Given this list of marker genes SAMD3, CRIM1, KANSL1L, DHX33, RAI1, CCNL2, CCZ1, IFT25, SLC35E2A, C5orf22, AP1S2, EOMES, ING4, L3HYPDH, CROCCP2 (NCBI Gene Id 84809), DCAF10, DOCK9, TFB1M, OMA1, METAP1, DCAF6, MTREX, CD300A, MTO1, DDI2, DNAAF10, NFATC3 (nuclear factor of activated T cells 3, NCBI Gene Id 82543), SLC4A1AP, CAPG, CSF2RA, GSTK1, PSMD14, CD84, RARS1, ANXA2, NBPF12, IRF3, VIPAS39, TBC1D9B, DIP2A, NUDCD1, UQCR10, DUSP18, RUVBL1, CISD1, ARMT1, ARMC8, FLT4 (fms related receptor tyrosine kinase 4), MEAK7, OGG1, LONP1, KIAA0319L, TMEM223, TDRD7, UBA1, HGSNAT, RETREG3, EXOC5, CBX1, STT3A, KHDC4, PRDX1, DLGAP4, ATPAF1, MAPK1, ZGPAT, EIF1, HNMT, SMARCAD1, AGAP4, MCMBP (minichromosome maintenance complex binding protein), CHD9, PNKD, EPS15, PDHB, IFFO1, PCMT1, EEA1, BICD2, IPO9, MED13L, CEP85, DARS1, SPOP, GALM, USP28, UBXN8, FAM111A, TM7SF3, HAUS1, HUWE1, LAT, OSGEPL1, SDAD1, ZNF354A, UVSSA, UBN2, FEZ2, ABCF2, ZNG1A, AHCYL2 (NCBI Gene Id 23382), MNDA, EIF2S1, MLEC, USP21, MRPL18, C3AR1, TRADD, HSD17B4, FADS1, SYNGR2, HDDC3, SRPRB, ZNF514, TES, DHX16, G3BP1, CTSC, IDE, SLC7A1, SRSF7, ZNF721, LUC7L, CRYBG3, SLC35B3, GIMAP2, GZMA, ZRSR2, GRSF1, MBNL2, LUC7L2, AKAP10, FUS, OXR1, RAD51C, WASH3P, AGPAT3, ELOVL1, TMEM50B, MRPS9, SLF2, HIBCH, CBFA2T2, IL17RA, ARHGAP26 (NCBI Gene Id 23092), RSBN1L, ALG13, KCNE3, ANAPC7 (anaphase promoting complex subunit 7), MUS81, NSRP1, RNF146, NUP43, GCN1, DNAJC17, C8orf44, ABRAXAS1, CPSF3, ESYT2, AP1AR, DNAJC16, MED11, ZNF148, TMEM250, ARL11, SKA2, PMS2P1, ETNK1, CACNA2D3, TTYH2 (tweety family member 2), NAPB (NSF attachment protein beta), TARDBP, PFKP, LRRC37A2, SLC30A7, CCZ1B (NCBI Gene Id 26113), STIP1, ME2, NNT, PURA, NBR1, STYX, CD4, H1-3, PCID2, MBNL1, ALG6, HEXB, LILRA4, MDM1 (Mdm1 nuclear protein, NCBI Gene Id 56890), RIOX2, MRS2, FCF1, CELF1 (CUGBP Elav-like family member 1), NUP42 (nucleoporin 42), CLPTM1L, HSPBAP1, NEAT1, UTP14C, WSB1, ARMC10, CASP2, NAIP, CDC14A, CIAPIN1, CAPRIN1, CBR4, CLPX, LRCH3, GGCT, COQ9, SLC25A11, ZNF573, LARS1, COMMD10, P2RX7, ATM, AMY1C, DPY30, TRAPPC8, HDHD2, PDHA1, COASY (Coenzyme A synthase), TIPRL, FKBP15, GNL2, DIDO1, SNAPIN, EIF2B4 (NCBI Gene Id 8890), ZNF641, BIVM, PAFAH1B1, USO1, ATP13A1, CD53, PREB, TK2, ZNF767P, BRD8, RBM42 (RNA binding motif protein 42), C2CD5, ECHDC1, RASA1, ZNF146, RSF1, IARS1, ENTR1, PPP3CB, SMC5, SCAMP1 (secretory carrier membrane protein 1), TMX3, GNPDA1, LGALS1, SCPEP1, AMY2A, DPP3, MTIF3, NHLRC3, NR2C2, EDEM3, NSF, NSUN5P1, POU2F2, RAB7A, NBPF1, LYRM7, APPBP2, STAG3L1, PMS1, HDAC9, GSAP, MRPS18B, MTIF2, ENSG00000272447, DUSP22, OTULINL, BRD10, ZNG1E, SLC7A6, NUDT7, NIT2, ACER3, GANAB, TNIP1, SIGMAR1, MACROH2A1, RAD50, DNM1L, NCOA3, PPIE, KDELR1, RBM8A, UBE4A, GSE1, YEATS2, SUGP2, SDCCAG8, KLHDC4, WDR12, EXOC4, C11orf21 (NCBI Gene Id 29125), VCAN, RASA4, B3GALNT2, NOTCH2, WDR73, TXNDC15, EIF3J, SAMHD1, CREBBP, FAM78A, UBA7, PRIMPOL, CDK4 (NCBI Gene Id 92978), RAD17, MRTO4, CD160, DOK2, POGZ, CACNA2D4, SLC66A3, NMT2, STK38, COX18, SPTLC2, IL27RA, SAE1, GPD1L, ARMC1, SLC38A10, SNX19, PRDX3, SP1, PIGG, SMC1A, DENND4B, SNUPN, ANAPC1, RTN4, PARN, COG2, CCND3, DIS3L, CUL1, TRAF5, CCT7, RAD1, MS4A7, KATNBL1, H2BC8, VIPR1, MKLN1, DDX23, ENGASE (endo-beta-N-acetylglucosaminidase), INTS8, GTF2E1, KAT2B, ZNF280D, ATP6AP1, PYCR2, PTGDR, LIAS, SHQ1, PNPT1 (NCBI Gene Id 87178), TTC9C, IP6K2, GALNT7, ZNF207, ZNG1B, NDUFA8, PAPSS2, CDC25B, CTSB, AGL, ITGB2 (NCBI Gene Id 3689), GPATCH4, RNPC3 (NCBI Gene Id 55599), INSR, PSD4, CREB3L2, AP1M1, COA5, MCM3 (NCBI Gene Id 4172), ORMDL1, SETX, INTS10, RASAL3, KDELR2, SPAST, MCCC2, GTF2A1, TBCK, PID1, AMY2B, FYB1, SAMD9L, SNX5, NCBP2, NCSTN (NCBI Gene Id 57297), TNFAIP8L2, RBM6, INPP4A, TMX2, NMRAL1, NAA25, MPHOSPH9, GLCCI1, HYOU1, NSUN5P2, TRIM44, TET2, CREB1, TTC1, SPCS2, DIS3L2, UBASH3A, RIPOR2, IRAK3 (NCBI Gene Id 11213), PIK3C3, APEH, TCTN3, GOPC, WBP1L, DCAF13, MICAL2 (NCBI Gene Id 9645), CLN8, TFCP2, EZH1, JAML, ASCC1, GPD2, HECA, FGD2, CASP6, CEP350, PITRM1, USP48, SULT1A2, PUS7, POLR3K, IQGAP2, RALA, GATAD1, COPS7A, CDK8, ATXN2, DCLRE1B, PAK1 (p21 (RAC1) activated kinase 1), NBPF9, MAD1L1, MGA, ZC3H6, VPS72, TMEM218, EWSR1, FKBP5, NDUFV3, YPEL2 (NCBI Gene Id 388403), OGFOD1, ZFP64, PDE6D, TRIM4, ALDH3A2, ATRN (NCBI Gene Id 8455), INTS13, EHMT1, CDC16, PRMT2, GSR, DCAF7, TBCE, ZDHHC13, PALB2, CRLS1, VPS50, PRKAG1, EIF4ENIF1, NFYC, KLHL8, KDM5A, NEK2-DT, G6PC3, TRIM56, RUSC1-AS1, ERI1, SRFBP1, KIDINS220, MBOAT1, BRWD1, ZNF862, ZNG1C, ZNF789, SNX1, PHF14 (NCBI Gene Id 9678), GIMAP6, GOT2, CYB5B, ADCY9, TARS1, RPS6KA1, HNRNPH2 (heterogeneous nuclear ribonucleoprotein H2), DPY19L4, WASHC3, SCRIB (scribble planar cell polarity protein), VKORC1, CNPY2, TIMMDC1, KLF6, MFSD8, BABAM1, TAOK1, ARL17A, M6PR, MRPS28, ECI2, MAVS, SCML4, GNPAT, DRAM2, NPAT, GCDH, RASSF4, PLPBP, MSH2, KRIT1, TGOLN2, TIMP2, LBH, CEP170, RETREG1, AK2, SLFN5, TRAPPC3, FNIP2, GIGYF2, INTS6L, COQ5, DECR1, PSMD1, TOR3A, MAPKAP1, TTC17, CD244, VAMP1, ZC3H14, SEC11A, OSTM1, DDX17, MON2, ZNF106, KLHL6, DEF6, CCR2, PSEN1, GCFC2, POT1, CLNS1A, SAP30L, UTP6, GLIPR1, TTC7A, UBTF, WASHC5, NCEH1, IKZF1, ITPRIPL2, PHF21A, JRK, KMT2A, SEC23B, WDR46, ATP8B1, COX10, SUCLA2, MIS18BP1, GPR89A, FAM118B, ANKIB1 (ankyrin repeat and IBR domain containing 1), KLHL7, SETD3, FCMR, TNFSF13, IRF5, AKIP1, POLI, CCT4, TRAF3IP3 (TRAF3 interacting protein 3), BTN3A3, NUMB, HSCB, CALHM2, LDAH, RSC1A1, NAA40, SULT1A1, UFSP2, LNPK, AZI2, CTSH, NME6 (NME/NM23 nucleoside diphosphate kinase 6), TARS3 (NCBI Gene Id 123283), DNAJA3, CLEC2D, EIF4A1, SEC23IP, COMMD3, DICER1, TTC13, YIF1A, GTPBP10, CLTC, VPS13D, ARSD, PACC1, SGPL1, SLC22A15, AMY1B, CYP4V2, XRCC5, METTL5, PSMA7, MOSMO, CAPRIN2, MPDU1, CHM, RALGAPB, CLK2, TERF2, RCAN1, APBB1IP, GALT, ZBTB40, MTCH2, MRPS6, NLRP12, ACSL5, GTF2H5, TRIQK, CD1D, PPP1R21, MOSPD2, CSNK2A1, GLG1, CYP20A1, ARHGAP30, NREP (neuronal regeneration related protein), ASCL2, DPYSL2, NUDT9, NCOA6, LDLRAP1, CCT6A, MEMO1, KCNK6, LPXN, ERG28, NCOR1, MID1 (NCBI Gene Id 8230), ABCD3, MRPL15, MPEG1, RGS14, PWWP2A, SLC35D2, DGLUCY, SKIC8, CD2, IL6R, VRK3, RBM5, EIF2S2, FUCA2, MRPL36, AMPD3, MLX, BIRC6 (NCBI Gene Id 57448), FLI1, SETDB2, FLT3 (NCBI Gene Id 2322), PRKAG2, GOLPH3L, DOCK10, ROCK2, MED12, STAB1, SSR3, RFXAP, DHPS, SPNS1, MRPL37, IER3IP1, SCARB2, MPHOSPH8, QSER1, C14orf119, ACAA1, NDUFS1, SFT2D1, QKI, ZC3H13, HDAC2, WDR77, RFC2, TNRC18, TOR4A, PREP, BAZ1A, ARF1, ATMIN, TIMM13, IDH1, CALML4, ABI3, EXOSC10, GIMAP4, STYXL1, SLC43A3, ALDH3B1, STING1, ZSCAN29, ARID1A, ADAP2 (NCBI Gene Id 55803), PARP4, SNORA28, EHBP1L1, ATF7IP, SF3B3, HMOX2, ZNF638, SOS1, CD164, CUL4A, TEX10, AUH (AU RNA binding methylglutaconyl-CoA hydratase), PCYOX1L, MKKS, SHMT2, JPT2, KLHDC10, PPM1L, ARSG, CANX, ASXL2, MICA, SYNCRIP, TFEB, SLC35A1, CLEC12A, RNASE2, CFAP298, UBAP2, RNASE6, TMEM260, GLT8D1, ITGA4, METTL2B, ACTL6A, METTL8, ASB3, TNFSF8, RNF213, C5orf15, ACAP2, JPX, SPG11, VPS35L, FBXO9, NEK4, RAB3D, CCM2, DNAJC7, IBTK, CRTAM, MTA1, EIF5B, AMY1A, SLC30A5, RAB27A, CAB39, LY9, TTL, TRMT13, NDUFAF1, NACC2, SEPTIN9 (NCBI Gene Id 8162), MCEE, MFSD4B, CCT5, WNK1, PDIA4, TRIM52, MRPL38, NEK7, CWC27 (CWC27 spliceosome associated cyclophilin), PCYOX1, PRPSAP2, RUFY2, LCK, ADCY7, GON4L, PTPN6, ABCC10, APTX (aprataxin), NBPF8, ZNF512, GMIP, LAMTOR2, NCBP1, RASEF, NLRC3, PMM2, LINC01138, OSTC, DENND2D, WASHC4, ACTR3, MTHFD1, PCM1, GGPS1, KRI1, ITK, XPO7, GPALPP1, UGGT1, FMC1, MRPL34, PIN4, RAB10, MRPS21, TRGC2, TMOD3, FBXO22, SNRPD3, PDIA6, SGMS2, ANAPC4, PPP1R2, SKIC3, PLRG1, REEP5, PAQR8, TFEC, MACF1, LACTB2, CEP83, TRAPPC6B, DENND10, DNAJC24, COMT, THEM4 (thioesterase superfamily member 4), HADHB, RSRP1, UCHL5, BRI3BP, SCFD1, SLC33A1, AVL9, RPRD1A, ANXA2P2, CABIN1, PDCD11, SRSF1, FCRL3, OTUB1, IMMT, APLP2, RPS6KA3, PMS2P6, ARIH2 (ariadne RBR E3 ubiquitin protein ligase 2), MCM5, BTN2A1, SARS1, RGS3, SERINC3, TMEM107, CREBL2, HEXA, CPOX, DCLRE1C, HNRNPF, INTS7, SERBP1, PRF1, MOB3B, PRDM2, RECQL, PRPF38A, CTNNA1, SESTD1, PILRB, WDSUB1, CHCHD4, LILRB1, PHB1, MRPL30, FARSB, RBM4B, DAB1, TRIT1, DAPP1, RAPH1, IPCEF1, SRGAP2C, APAF1, ANXA4, TGFBI, TRIM66 (tripartite motif containing 66), TTC14, ADH5, SLAMF6, AQR, CRYZL1, LRRC47, SLC25A40, SSR1, ANKFY1, TMEM216, TADA3, TSPAN14, API5, GLB1, FAM117A, PAM, ANKRD10, RAC2, PRPSAP1, SETD5, PIGF, TOMM5, AHSA1 (activator of HSP90 ATPase activity 1), MSL3, RHOB, BTBD7, EPRS1, DIAPH1, SYNRG, PHKA2, SEC63, AHCYL1, CAPN3, STAM2, BCL2, NVL, DUSP7, NPEPPS, ACTMAP, KMT5B, NELFB, TXN2, COPS5, CES2, LARP4B, TPCN1, PMS2P5, RMND1, RNASEH2C, NSMCE4A, REV1, COQ2, FGD4, GMPR2, MCM3AP, SAMM50, CPM, MZF1 (NCBI Gene Id 90814), ESYT1, CISD3, APOBEC3G, TTC27, CLOCK, MRI1, QRSL1, CX3CR1, HELZ, SMARCA2, MORC2, FTSJ3, CDC7, OGT, TMEM14C, DNAAF5, SPN, RHOT1, NAAA, LRIG2, EEF1A1, BTN2A2, UBE2L3, IRF8, PLCB1, XPO1, COPZ1, ALG10B, MGST2 (microsomal glutathione S-transferase 2), TRIM27, TNFSF12-TNFSF13, CLCC1, MGAT2, MTMR11, HPF1, NDFIP1, USP34, ORC2, FAM219B (NCBI Gene Id 57184), GPR171, TIA1, SUSD3, PDCD6IP, ANKZF1, VBP1, PSTPIP1, NSUN5, KIZ, ASRGL1, LRRC8D, KLRG1 (NCBI Gene Id 10219), TRRAP, ATP2B4, HS2ST1, COPB2, GIN1, GPR75, UBXN11, MAP4K4, SLC46A3, JUN, NID1, CNTRL, SPG7, ERAP1, GART, ATF7IP2, PRDM15, FBXW2, CEP104, POLK (DNA polymerase kappa), NASP, BTN3A2, TSPAN32, SH3TC1, HERC4, NDC1, CXorf38, AHNAK, PPP6R3 (protein phosphatase 6 regulatory subunit 3), ZNF439, TMED10, IPO8, MGST1, TCHP, INTS3, CREBZF, CARS1, ARL17B, RPA2, SNX27, TATDN1, PRKACB, METTL3, TRAPPC11, MARCHF1 (membrane associated ring-CH-type finger 1), UPF3A, PAAF1 (NCBI Gene Id 80227), DTD2, PPP1R12A, PSPC1, TRIM33, SAP30, HPS3, THOC2, LCORL, SLC12A2-DT, PRR14L, HERC2P3, LONP2, VAMP4, CNOT1, TMEM168, HDAC1, SON, ATP8B2, CPSF1, KIAA0930, UBE2V2, RDH11, TCF12, CIRBP, SIRPB2, METTL13, MYCL, HDLBP, TAPT1-AS1, PIGV, APOBEC3F, GPATCH2, CASP8AP2, NFATC2IP, HYCC1, PDZD11, EXT2, SULT1A3, PDHX, MRPL57, GAB3, CASP1, TRPS1, MANBA, TXK, MTX2, MTRF1, PEX11B, PCMTD1, KYAT3, MDFIC, ICAM2, GVINP1, TP53, MPV17, TCAIM, MED1, SFXN4 (NCBI Gene Id 94084), MS4A6A, RNF170, DTNBP1, LPP, RAB3GAP1, AKAP11, MITD1, CHMP4A, METTL17, MTDH (NCBI Gene Id 92140), SLC25A43, UBA3, RUVBL2, TSEN2, FBXL20 (NCBI Gene Id 90110), TNPO3, PPP4R3B, PHYKPL, CSNK1A1, ZNF248, CD33, NUP210, TMEM248, BMP2K, TMEM80, RAB29, PSMC4, SLC44A1, ARHGEF10L, STX7, DELE1, MRPL48, ARV1, AIFM1, LGALS3, ATP6V0E1, HLTF, STRAP, MYDGF, NUP62, AFG2A (AFG2 AAA ATPase homolog A), SP3, C9orf72, KLRD1, PCCA, ZNF559, DIAPH2, CENPB, CD58, THYN1, CPNE3, SENP6, ST3GAL1, TRAM2, BRD3 (NCBI Gene Id 9763), NDUFA10, ATP2C1, VDAC3, EVL (Enah/Vasp-like), ACADM (acyl-CoA dehydrogenase medium chain), PPID, CCT3, EFL1, ZSWIM6, LAIR1, CD1C, TRIM73, PPP2CB, PMS2P2, DHRS4-AS1, HADH, HIKESHI, DDX19A, MAP3K7, TSC1, PAXBP1, PSME3IP1, SLAMF1, MOB1B, ATP6V1C1, GBA2, PCNX4, OSBPL11, GATC, OGDH, SIN3B, LUC7L3, ATG3, DCP1B, OLIG1, RASGRP1, HIVEP3, ITPKB, PSAP, DDX41, PARVG, VPS52, ZNF664, RPS27A, HMBOX1, MMS19, HEATR3, SUN1 (Sad1 and UNC84 domain containing 1), ZNF302, CTBP2, ST6GAL1, TMEM214, USP33, TENT2, GPR89B, SKP2, GATD3, GAPT, ACLY, VPS8, C6orf89, SNRNP40 (NCBI Gene Id 9410), KCTD12, SETD4, YIPF5, GLS, DNAJC13, AP4B1, AGK, SS18, ECPAS, BAZ1B, STK17B, IKBKB, TDRD3, FYN, VAMP8, LIMD1, LNPEP, DCPS, AP4E1, HADHA, ALG8, EYA3, TMEM87B, SYTL1, ATPSCKMT, POP5, RPE, POLR1D, FASTKD1, CHCHD3, TASOR, MYO1G, RPAP2, MPLKIP (M-phase specific PLK1 interacting protein), AIDA, RAB28, FBXW11, UBA5, HNRNPAB, GOLGA5, PLGLB1, ZFC3H1, PDE7A, MRPL14, MARS1, TM2D1, SRGAP2, SPIN3, FAM200B (NCBI Gene Id 285550), PIEZO1, MCTS1, FTX, MRPS5, VPS36, ATL3, SUGT1, BDP1, PTPN22, GUSBP2, CD163, SP140, RAP1GDS1, IPO7, PFDN6 (prefoldin subunit 6), CMAS, SEC22A (SEC22 homolog A, vesicle trafficking protein), ABRACL, AARS1, STX12, FNBP1, RAPGEF6, HDHD5, ANKRD17, HSD17B12, SLC18B1, CLCN3, LINC00324, COPA, EXOC1, C15orf40, CDK2AP2, TMCO1, ARL6IP5, PSMG1, ZNF75D, EMSY, BRCC3, LY86, FNTA, NEK9, ACAT1, SLC25A45, DNMT1, ZW10, NBPF11, SLC26A2, CLTA, ZNG1F, REEP3, LMAN2, PIGM, LMAN2L, WDFY2, PHF20, ADHFE1, ELAVL1, PSMA3-AS1, CACYBP, STAMBP, ATP6V0A2, ABCB7, ELK3, AKAP13, TLR5, CIAO1, ZNF224, PRKCD, HPCAL1, SH3BP5, CARNMT1, ATP6V1D, ARHGAP27, SMG1, TRAPPC12, GALNT1, BATF, ZFP90, CGGBP1, BPTF, CNOT4, ZBTB48, UQCRC1, C11orf54, TPP1, TMPO, TUT4, RBBP4, POC5, AMMECR1, CEPT1, MS4A14, VPS35, TMEM165 (NCBI Gene Id 55858), NADSYN1, FIG4 (FIG4 phosphoinositide 5-phosphatase), WRAP73, SRSF3, SPART, ANXA6, CYBRD1, ZKSCAN1, NOTCH2NLA, MEX3C, WDR11, LETMD1, STX6, CIDEB, SLC46A2, SNHG10, SULT1A4, PLGLB2, ITGAL, POLR1B, LYSET, ZDHHC16, CPNE2, MRPS14, NT5C2, XIAP, SDHC, FLII, OSBPL3, ADSL, ADISSP, SLC25A46, UTP14A, CLIP4, CARD8, CENPJ, SPTSSA, METTL2A, KLHDC3, PITPNB, FH, SLC35A5, HM13, MALAT1, CPSF2, VPS16, SELPLG, NLRC4, SUPT16H, DFFA, PTER, RCSD1, AP3S2, MRE11, DNAJC10, ATP5MC1, TMOD2, NPIPA1, WDR59, RBM41, PHF20L1, TSNAX, TAOK3, NMT1, PUM1, TUG1, NARS1, EEF2K, IQGAP1, TRIM13, GTF2H1, AHSA2P, PYHIN1, SEC31A (SEC31 homolog A, COPII coat complex component), LRIF1, UQCC1, ECH1, PTGR3, SLAMF7, PDIA5, C1orf162, VTA1, HOOK3, HELQ, ANKLE2, SHPRH, ARMH3, SETDB1, N4BP2L2, SMARCA4, S100PBP, NFATC2, CFDP1, FLAD1, WDR33, CRACR2A, HCG18, C2orf74, ZNF518A, NIPBL, STAT6, DGKZ, PDE4DIP, PIH1D1 (PIH1 domain containing 1), FAM114A2, EFCAB14, NEMP1, KRTCAP2, ALKBH3, CNOT6, RER1, RBM14, TMEM63A, PBRM1, SLC38A9, ELP3, GEMIN7, IL7R, MLXIP, GEMIN6, DHX32, SMARCAL1, RECK, KRCC1, ANKH, ATF1, SUPT20H, STX18, RABGAP1, TMEM69, CD27, GOLGA3, FBH1, GET3, KCTD15, RASGEF1A, RTN1, HEXD, COX15, CLEC12B, MAPK1IP1L, SCOC, ATG7, RCBTB2, CLIC3, RSPRY1, ZMYM6, ZNF609, HENMT1, CEP164, RNF111, TRAC, MBP, RNASE4, DYM, APOBEC3C, NADK, SNTB2, TCF7L2, MAP3K20, MRPS31, CCDC88A, ZMYM4, TBC1D10C, TAF15, CSF1R, DDX46, IFI16, VPS45 (vacuolar protein sorting 45 homolog), GIMAP8, TRPV2, TARP, TRIP4, UBTD2, NIT1, RXYLT1, RAB3GAP2, DAGLB, TSEN15, NUDT16, FZD2, GIMAP1, APPL1, EIF3B, BFAR, MEF2A, POGLUT1, COMMD1, AIMP2, TM9SF4, NBPF10, NUDCD3 (NudC domain containing 3), UGP2, POLR2J2, here is a description of the gene set: Human Gene Set: NAKAYA_PBMC_FLUMIST_AGE_18_50YO_7DY_UP from publication Nakaya HI, Wrammert J, Lee EK, Racioppi L, Marie-Kunze S, Haining WN, Means AR, Kasturi SP, Khan N, Li GM, McCausland M, Kanchan V, Kokko KE, Li S, Elbein R, Mehta AK, Aderem A, Subbarao K, Ahmed R, Pulendran B (PMID 21743478) Genes up-regulated in peripheral blood mononuclear cell 7d vs 0d in adults (18-50) after exposure to FluMist, time point 7D. Comment: Supplementary Table 1b: All the differentially expressed genes identified in PBMCs of TIV vaccinees. species: Homo sapiens Here we have used a systems biology approach to study innate and adaptive responses to vaccination against influenza in humans during three consecutive influenza seasons. We studied healthy adults vaccinated with trivalent inactivated influenza vaccine (TIV) or live attenuated influenza vaccine (LAIV). TIV induced higher antibody titers and more plasmablasts than LAIV did. In subjects vaccinated with TIV, early molecular signatures correlated with and could be used to accurately predict later antibody titers in two independent trials. Notably, expression of the kinase CaMKIV at day 3 was inversely correlated with later antibody titers. Vaccination of CaMKIV-deficient mice with TIV induced enhanced antigen-specific antibody titers, which demonstrated an unappreciated role for CaMKIV in the regulation of antibody responses. Thus, systems approaches can be used to predict immunogenicity and provide new mechanistic insights about vaccines.